The following is a description of a gene set: Genes up-regulated in dendritic cells: immature versus mature stimulatory. Human Gene Set: GSE9946_IMMATURE_VS_MATURE_STIMULATORY_DC_UP studied in species Homo sapiens Myeloid dendritic cells (DC) and macrophages play an important role in pathogen sensing and antimicrobial defense. Recently we demonstrated that infection of human DC with intracellular bacterium Listeria monocytogenes (L.monocytogenes) leads to the induction of the immunoinhibitory enzyme indoleamine 2,3-dioxygenase (Popov et al., J Clin Invest, 2006), while in the previous studies L.monocytogenes infection was associated with a rather stimulatory DC phenotype. To clarify this discrepancy we performed comparative microarray analysis of immature mo-DC (immDC), mature stimulatory mo-DC (matDC) and mature inhibitory DC either stimulated with prostaglandin E2 (PGE2-DC) or infected with L.monocytogenes (infDC). Studying infection of human myeloid DC with Listeria monocytogenes, we found out, that infected DC are modified by the pathogen to express multiple inhibitory molecules, including indoleamine 2,3-dioxygenase (IDO), cyclooxygenase-2, interleukin 10 and CD25, which acts on DC as IL-2 scavenger. All these inhibitory molecules, expressed on regulatory DC (DCreg), are strictly TNF-dependent and are in concert suppressing T-cell responses. Moreover, only DCreg can efficiently control the number of intracellular listeria, mostly by IDO-mediated mechanisms and by other factors, remaining to be identified. Analyzing publicly acessible data of transcriptional changes in DC and macrophages, infected by various pathogens and parasites (GEO, GSE360), we noticed that infection of these cells with Mycobacterium tuberculosis causes transcriptional response, comparable with the one caused by listeria in human DC. In fact, granuloma in tuberculosis and listeriosis in vivo are enriched for myeloid DC and macrophages characterized by regulatory phenotype. In summary, regulatory myeloid DC and macrophages may play a dual role during life-threatening granulomatous infections, such as tuberculosis: on one hand, regulatory myeloid cells promote pathogen containment by efficiently killing intracellular bacteria, on the other hand these cells inhibit granuloma-associated T cells and thereby might be involved in the retention of TNF-controlled granuloma integrity protecting the host from granuloma break-down and pathogen dissemination. from publication Popov A, Driesen J, Abdullah Z, Wickenhauser C, Beyer M, Debey-Pascher S, Saric T, Kummer S, Takikawa O, Domann E, Chakraborty T, Krönke M, Utermöhlen O, Schultze JL (PMID 18802101), and this is the list of marker genes: SIAE, TMEM9B, SRP72, HINFP, PLCXD2, CD5, FMNL1, NUP210, SFRP4, TMC5 (NCBI Gene Id 79838), FBRS, ATXN7L3, MAT2B, CAND1, TGFBR3, ADSS2, AMPD1, SNCA, PPP1R15B, SLC6A5, ITGA6, MOSPD3, ERLIN2, ZFP30, DDX23, SPAST (NCBI Gene Id 6683), CBFA2T2, DYNC1LI1, MAGEB17, OGN (osteoglycin), KRT27 (NCBI Gene Id 342574), MMP20, MAPK6, CYP4X1, CTDNEP1, CDKN2AIP, BTRC, FAM50A, ROM1, RNF123, POM121L2, STAT3, SLC35E1, PXYLP1, ZBTB9, CMBL, SNX4, DSE, NSA2, LNX2, TMEM81 (NCBI Gene Id 388730), KRT8, IL21R, TCF4, RALBP1, H1-3, SMAP2, CHCHD3, ESRP2, PNMT, CHMP4C, EML1, GPR101, RASGRP2, SH3BP5, CHGB, EIF2S2, VAV1, MIR488, SLC66A1, MIR217, TERB1, OCLN, FCGRT, SARNP, MIR340, AP3S1, VRK3, NEPRO, PLAAT3, TTC38, ABRA, WSB2, NDOR1, MFSD6, METTL8, UIMC1, CCNK, SETD1B, TTC7B, ATP6V0D1, ALS2CL, NUDCD3, SLC13A2, CHIC2, NAT1, FAS, ZFP36, DDR1, TRIM26, ADD1, ZFAND3, RPL7A, ACY3, TSPAN1, AQP11, SPRR3, HYLS1, TTC3, GGCX, PRRT3, RDH5, XDH, DNAJB9, KLHDC2, GPRIN2, ZNF394, ARHGAP29, FGD5, FAM170A, IL17RA (NCBI Gene Id 23765), ZXDC, RBBP5, NEBL, WDFY1, SAP30BP, LIMS1, AXIN2, TAS1R3, STAT6, FAF2, DAB1, OLR1, SEH1L, MBD6, TLE1, RRAGD